Given this list of marker genes UQCR10, UQCRQ, UQCRB, TTC19, UQCRC1, LYRM7, MT-CYB, UQCC3, UQCRH, UQCC2, UQCR11, BCS1L, UQCRFS1, UQCRC2, CYC1, UQCC1, here is a description of the gene set: Human Gene Set: WP_MITOCHONDRIAL_COMPLEX_III_ASSEMBLY species: Homo sapiens Mitochondrial complex III assembly